Given this list of marker genes MICALL2, CDK5, ATP5IF1, SIAH3 (NCBI Gene Id 283514), LRRK2, RAC2, KCNB1, SLC1A1, CSNK2A2, TOMM7, CHP1, HPCA, CDKN2A, HAX1, PDZK1, RNF31, MIEF1, SAE1, BAG3, USP36, STOM, PINK1, SREBF2, PRNP (prion protein (Kanno blood group)), UBE2D3, CDK5R1, HSPA1L, SLC51B, FZD5, MTCL1, HUWE1, UBE2L3, TOMM70, INPP5K, C11orf65, ADCY10, PRKN, C2CD5, LMAN1, CIB1, ARIH2, BAP1, GDI1, BNIP3L, GSK3A, PARL (presenilin associated rhomboid like), ANK3, DMTN, MYO1C, ITGAM, AKT2, TCAF1, FYN, HTRA2, KCNE1, ABLIM3, USP17L2 (NCBI Gene Id 392198), FBXW7, RHOU, HRAS, ITGB1BP1, LEPROT, BAG4, HPS4, ERBB2, CEMIP, UBL5, UBE2J2, ITGB2, SH3GLB1, MIEF2, ATG13, VPS11, NPEPPS, PAK1, TCAF2, UBL4B, PRKAA1, SREBF1, here is a description of the gene set: Any process that modulates the frequency, rate or extent of protein targeting. species: Homo sapiens Human Gene Set: GOBP_REGULATION_OF_PROTEIN_TARGETING